Given this list of marker genes FGA, FBXO41, MAPK6 (NCBI Gene Id 5597), NXF2B, ANKIB1, GTPBP1, HSBP1L1, DTNBP1, GPR55, SLC16A2, KRTAP5-6, SGK2, PCBP2, PPP3R1, MED13L, PHF8, TTYH3, ROBO2, NXF2, IL1RAP (interleukin 1 receptor accessory protein), FBRS, NRIP2, KCNAB2, MGAT5B, GRAMD2A, PURA, SH3KBP1, SORCS2, SESTD1, PDZRN3, TMEM217, SIPA1L1, PATZ1, MCCC2 (NCBI Gene Id 64087), NMUR1, ARMC8, TGIF2-RAB5IF, HIVEP3, GSG1L, TAB2, ASCC1, FMNL3, COBL, ALOXE3, RAB5IF, ROPN1, NSG1, ZMIZ1, THG1L, MYORG, UCK2, PALLD, KCNH4, RAB14, RIMS2, SNX19, SMURF1, CXXC4, SYDE2, GCNT4, ZYX, PPARGC1B, LRP2BP, CALN1, here is a description of the gene set: from publication Chen Y, Wang X (PMID 31504780) Human Gene Set: MIR1293 Genes predicted to be targets of miRBase v22 microRNA hsa-miR-1293 in miRDB v6.0 with MirTarget v4 prediction scores > 80 (high confidence targets). studied in species Homo sapiens